The following is a description of a gene set: part of: MTOR signalling This event has been computationally inferred from an event that has been demonstrated in another species.<p>The inference is based on the homology mapping from PANTHER. Briefly, reactions for which all involved PhysicalEntities (in input, output and catalyst) have a mapped orthologue/paralogue (for complexes at least 75% of components must have a mapping) are inferred to the other species. Reactome Pathway: mTORC1-mediated signalling electronically inferred by orthology from the curated human pathway studied in species Mus musculus, and this is the list of marker genes: Eif4ebp1, Lamtor1, Rps6kb1, Fkbp1a, Lamtor2, Rps6 (ribosomal protein S6), Lamtor4, Akt1s1, Rraga, Lamtor5, Rragc, Rheb